The following is a description of a gene set: Human Gene Set: HP_ABNORMAL_INCISOR_MORPHOLOGY studied in species Homo sapiens Abnormal incisor morphology An abnormality of morphology of the incisor tooth., and this is the list of marker genes: ARHGEF38, FARS2, DPH2, CTCF, NAA80, KCNMA1, NEK1, CKAP2L, PPP1R13L, NECTIN1, EP300, EDA, BRD4, DLG1, CREBBP, ARHGAP29, CACNA1I, CHSY1, TBC1D24, NHS, RIC1, ATR, VPS13B (vacuolar protein sorting 13 homolog B), ST14, GJA1, DYNC2LI1, KCNK9, PURA, LRP6, CCBE1, EDARADD, IKBKG, KAT6A, WNT10A, BRF1, SUMO1 (small ubiquitin like modifier 1), PDGFRA, EVC2, BMP4, EVC, MSX1, B3GLCT, PAX9 (NCBI Gene Id 5083), RPS6KA3, IRF6 (NCBI Gene Id 7452), FGFR2, PRKACA, FGF3, GLI1, ABCC9, CDH1, TP63, PACS2, ATP6V1B2, GRIA3, PRKACB, DLX4, AXIN2, COBLL1, TGFA, FGFR1, COL11A1, WNT10B